The following is a description of a gene set: The process, occurring after embryonic development, by which the anatomical structures of an appendage are generated and organized. An appendage is an organ or part that is attached to the trunk of an organism, such as a limb or a branch. studied in species Mus musculus Mouse Gene Set: GOBP_POST_EMBRYONIC_APPENDAGE_MORPHOGENESIS, and this is the list of marker genes: Mir23a, Large1, Atrx, Enpp1, Vps54